The following is a description of a gene set: The change in morphology and behavior of a mature or immature T cell resulting from exposure to an antigen for which its T cell receptor is specific bound to an MHC molecule on an antigen presenting cell, leading to the initiation or perpetuation of an immune response. Human Gene Set: GOBP_T_CELL_ACTIVATION_VIA_T_CELL_RECEPTOR_CONTACT_WITH_ANTIGEN_BOUND_TO_MHC_MOLECULE_ON_ANTIGEN_PRESENTING_CELL species: Homo sapiens, and this is the list of marker genes: APBB1IP, TREM2, PLXNA1, FGL2, TYROBP, HLA-DMB (major histocompatibility complex, class II, DM beta), LGALS3, CD81, LGALS9, LILRB1, ICAM1, HAVCR2, SEMA6D, ITGAL